Given this list of marker genes Cpox, Epha6, Or5ac20, Nsun3, Olfr184-ps1, Or5h18, Or5k16, Tbc1d23, Filip1l, Or5k17, Gm4660, Or5h25, Or5h21-ps1, Or5h23, Gm7366, Gm8881, 4930461C15Rik, Gm46541, Epha3, Gm21050, Gm25617, Or5ac19 (NCBI Gene Id 258996), Riox2, Gm23180, Gm22769, Gm26369, Impg2, Nfkbiz, Or5k14, Gm5487, Mir5118, Or5ac21, Gm23852 (NCBI Gene Id 115488714), Gm18870, Cep97, Rpl7a-ps4, Gm9017, Gm19771, Gm18723, Or5h24, Lnp1, Arl6, Or5k1b, Gm20942, Or5ac23, Gabrr3, Cmss1, Zpld1, Or5k3, Gm22977, Gm26800, Or5k1, Gm17809, Gm9061, Arl13b, Or5h17, Tmem30c, Nit2, Gm24164, Gm19000, Ftdc1, Gm15693, Or5ac22, Vgll3, Or5ac25, 4930453N24Rik, Or5ac18, Chmp2b, 4921517D16Rik, Or5k15, Rpl24, Gm8900, Or5ac16 (olfactory receptor family 5 subfamily AC member 16), Tfg, St3gal6, Gm26019, 4930547E14Rik, Gm22429, Gm9816, Gm17192, Gm8938, Or5ad1-ps1, Or5h20-ps1, Or5ac15 (olfactory receptor family 5 subfamily AC member 15), Gm16892, Zbtb11os1, Stx19, Gm9027, Gm22422, Dcbld2, Gm5674, Csnk2a2ip, Htr1f, Adgrg7, Pros1, Nxpe3, Gm16385, Or5h22, Ftdc2, Cldnd1, Zfp654, Gpr15, Tmem45a, 1700010K23Rik (RIKEN cDNA 1700010K23 gene), Gm25853, Trmt10c, Or5h27, Abi3bp, Gm33912, Or5ac24, Or5h26, Tomm70a, Pou1f1, Col8a1, Or5ac17, Senp7, Tmem45a2, Or5h19, Or5k8, Cggbp1, Zbtb11, Gm5221, Crybg3, Gm9584, Pcnp (PEST proteolytic signal containing nuclear protein), 1700022E09Rik, here is a description of the gene set: Mouse Gene Set: chr16C1 studied in species Mus musculus